Given this list of marker genes RGS1, MRAP, GHRHR, ADGRG5, MCHR1, S1PR4, ADGRF2P, ADCY8, OPRK1, GNAT1 (NCBI Gene Id 2779), DGKQ, GPRC6A, GPR26, AKAP12, ADGRF3, MC1R, CRHR2, ADCYAP1 (NCBI Gene Id 116), RAPGEF3, GPR68, ABCA1, NHERF1, MC5R, DRD5, GNAT3, GRIK3, GNG2, RAMP2, TBXA2R, ADGRG4 (adhesion G protein-coupled receptor G4), CHRM4 (cholinergic receptor muscarinic 4), GABBR1, CXCL10, CXCL11, PDE3A, GPR62, CALCB, PDE3B, CHGA, TAAR9, FFAR3, CNR1, PRKAR2B, ADGRL1, ADORA1, ADCY4, ADGRB2, ADM5 (adrenomedullin 5 (putative)), POMC, GNB1, OR1G1, ITGB3, RIMS2, LPAR2, S1PR1, CALCRL, GPR37L1 (G protein-coupled receptor 37 like 1), CHRM2, MAS1, GNA12, RXFP1, APLP1, PTGDR2, GPR12, AVPR2, ADCY7, GPR78 (G protein-coupled receptor 78), GRK5, ADORA2B, LPAR3, ADCY1, HTR1F, GRM5, CRHR1, GRM3, ADRA1B, ADGRG6, OPRM1, OR51E2, ADGRD1, ADGRG3, GPR61, PRKACB, VIPR2, EDN1, PTHLH, DRD4 (dopamine receptor D4), ADGRE1, AKAP5, DRD2, CHRM5, MC3R, GCG (glucagon), GRM1, PTGER4 (prostaglandin E receptor 4), TAAR6, GNAQ (G protein subunit alpha q), HTR1D, ADCY3, VIP, ADRB1, GRM8, GRM2, S1PR2, CXCL9, GABBR2, GPR4, ADGRB1, GNA13, RIT2, TSHR, ADRB2, ARRDC3, CACNA1D, PDE2A, PRKCA (protein kinase C alpha), HTR6, NOS1, ADGRG1, NPY2R, GRM4, GLP2R, GNAO1, GPER1, OR5AN1, GNA11, ADGRE2, ADGRB3, HTR4, HTR1B, MC4R, AKAP6, OPRL1, IAPP, MC2R, PF4, INSL3, ADCY9, MRGPRD, ADGRG2, HTR7, OR1E3, PRKACA, ADRA1D, GNAL, GPR161, GPR37, ADRA1A, ADGRL2, PDE10A, OXER1, ADRB3, MAPK7, SCT, MIR30E, ADCY2, RXFP2, PTGER3, ADORA2A, GLP1R, PSAPL1, HRH4, GIPR, PRKAR2A, HTR1A, WASF2, PRKAR1B, ATP2B4, ADGRD2, CRTC3, GPR6, ADRA2A (adrenoceptor alpha 2A), GPR176 (G protein-coupled receptor 176), RGS2, SCTR, GPR119, GNAI2, VIPR1, GPBAR1, GALR1, RIC8A, S1PR3, DRD3, FFAR4, RAMP3, RAMP1, MTNR1A, GPR65, GALR2, CASR, GIP, DRD1, GPR157, PLN, PRMT5, GPR171, GNAT2, PTH1R, ADCY5, APP, GCGR, ADCY10, CHRM1, PDE4B, TAAR1 (trace amine associated receptor 1), GPR3, LPAR1, GPHB5, GPR88, CCR3, ADGRG7, GNAI1, UCN2, GSK3A, PALM, TCP11, PRKAR1A, PDE4D, FLNA, HTR5A, GNAI3, APLNR, GRM7, PTGFR, CNR2, PTH2R, ADM2 (adrenomedullin 2), CXCR3, ADCYAP1R1, RAPGEF4, MRAP2, ADGRF4, MGRN1, LHCGR, PDE4A, CORT, SSTR2, PSAP, GPR146, MARCO, S1PR5, P2RY12, FPR2, ADGRL3, ADM, ADCY6, PTGER1, UCN3, P2RY1, ADGRL4, GALR3, HTR1E, HRH3 (histamine receptor H3), CALCA, GPHA2, FSHR, GPR101, GHRH, GRM6, MIR133A1, ADGRF5, PTGER2, PTGIR, ADGRE5, FPR1, OPRD1, PTH (NCBI Gene Id 5741), RAPGEF2, EDNRA, TAAR5, GNAZ, CALCR, ADGRF1, GNA14, RACK1, CHRM3, NPY1R, ADGRE3, GNAS, here is a description of the gene set: Human Gene Set: GOBP_ADENYLATE_CYCLASE_MODULATING_G_PROTEIN_COUPLED_RECEPTOR_SIGNALING_PATHWAY studied in species Homo sapiens A G protein-coupled receptor signaling pathway in which the signal is transmitted via the activation or inhibition of adenylyl cyclase activity and a subsequent change in the intracellular concentration of cyclic AMP (cAMP).